The following is a description of a gene set: studied in species Mus musculus Mouse Gene Set: GOBP_REGULATION_OF_INTRACELLULAR_STEROL_TRANSPORT Any process that modulates the frequency, rate or extent of the directed movement of sterols within cells., and this is the list of marker genes: Ldlrap1, Abca2, Tmem97, Anxa2, Arv1, Scp2, Nus1, Pcsk9